The following is a description of a gene set: species: Homo sapiens Genes having at least one occurence of the motif AAAGACA in their 3' untranslated region. The motif represents putative target (that is, seed match) of human mature miRNA hsa-miR-511 (v7.1 miRBase). Human Gene Set: AAAGACA_MIR511, and this is the list of marker genes: RAB22A, PCARE, RHOJ, NACC1, TRAPPC8, PHAF1, ZDHHC21, TRIM2, ADSS2, KLHL18, PAX8, BUB3, MIB1, CCNT2, CCDC178, POU4F2 (POU class 4 homeobox 2), DDX3Y, CAPRIN1 (NCBI Gene Id 4076), ABCG8, TRIM24, VANGL2 (NCBI Gene Id 57216), NLK, SPTLC2, BCL11A, REV3L, CALM1, LRCH4 (leucine rich repeats and calponin homology domain containing 4), PMEPA1 (NCBI Gene Id 56937), ZNF319, CNOT4, SS18, MAP4K4, ACE, PELI1, GFAP, SELENOP, TIAL1, ANAPC15, EMILIN2, SPTBN4, LMCD1, GEMIN2, NXPH1, MAPK1IP1L, NEUROD6, CFAP298, TBXT, MTAP (NCBI Gene Id 8008), BTG1, VKORC1L1, EYA4, FNDC1, FNDC5, ALCAM, DEDD (death effector domain containing), CCND1, TSPOAP1, EPHA4, CREBRF, RAB2A, SATB2, FGF13, SLC25A26, MRPL21, ATL2, HLTF, RGL1, ATRX, CORIN, ANKRD40CL, DCTN4, FAM117A, KCNE1, ST18, TRAPPC3, PHLPP1, ZNF654, VMP1, CAMTA1, MDGA2, TOB1, VAV3, PSMA1, SYT11, PPARGC1A, CDH2, PSMD10, SLC6A6, E2F3, DUSP6, MINK1, CELF1, HLF, SMARCE1, DDX3X, KCNMA1, TNRC6A, SRGAP3, YTHDF2, METAP2, SCN4B, EDEM3, ILRUN, ARHGEF17, TNRC6B, CDK14, NRXN3, GLRA2, IGF2BP1 (insulin like growth factor 2 mRNA binding protein 1), AGO1, TMEM248, CRIM1, FOXN3, TXNL1, FOXK2, ANKZF1, CLTC, AGO4, MBD2, RHOT1, NR4A2, CAMK2N1, HOXA13, SOST, RECK (reversion inducing cysteine rich protein with kazal motifs), SOCS2, NTRK2, FMR1, C1QL2, PIK3R3, TMEM196 (NCBI Gene Id 256130), ONECUT2, VIRMA, ELAVL3, PCDH10, DNAJB12, SORCS3, RBM26, EML4, C1orf21, ROBO2, RBM15B, LPP, KLHL24, LUC7L3, SEMA3F, RPS6KL1, EYA1, LATS1, MSTN, PRP4K, DYRK1B, QKI, ADGRF5, AGBL3, SEMA6D, NHLH2, CELF6, EFR3A, UBE2H, IGF2BP3, ESRRG, KHDRBS2, AGO2, ENPP1, HCN4, YY1, PTGR3, POGK, NAA50, FN1, PCDH17, THOC5, SLITRK1, MYO19, RPS6KB1, ATP2B2, ENPP4, TMEM243, RNF19A, ZNF706, MAP3K2, PRELP, WNT16, ZCCHC24, CEP350, DSC1, SINHCAF, HAS2, ADAMTSL3, CDK19, GJA1, DNAJC13, FIP1L1, KLF9, TAF5, GAD2, CLK2, SLC22A17, SOX12, AQP6, MYCBP, CREM, MBD6